Given this list of marker genes STAU1, FGD6, TMEM33, NTS, LRRC4C, PIK3CA, SEMA3A, RHOU, ENPEP, MTERF1, TRHDE, MSL3 (NCBI Gene Id 25867), RIOK2, POLI, PI15, KAZN, PPP2R3A, GABRG2, PTPN21, AMD1, PABPC3, PEX1, ZFP91, MARCHF1, FNDC3B, XRN1, ARHGAP5, C2orf66, HCN1, CYBRD1, PABPC4L, FAM13C, AKAP12, ATR, PPP4R2, ABHD5, MAP3K20, PATL2, TOR1AIP2, CWC15, ELOVL5, DFFA, UBAP1, NMU, ETV1, SLC4A7, HCFC1, KCNA4, NGLY1 (N-glycanase 1), TUSC1, KCNMA1, AASDH, HS3ST1, ZNF99, SH3TC2, PEX5L, ANOS1, RFPL1, EPHA5, MAP4, RSBN1, KRT38, EGLN1, ARID2, FXYD3, MBNL2, SLC1A1 (solute carrier family 1 member 1), LATS1, USH2A, RDX, MKRN1, ZDHHC20, TMEM263, GK5, STC2, PID1, HADHB, ZMYM5, YME1L1, CHUK, RBM18, MFSD14A, VCAN, FAM210B (NCBI Gene Id 81895), ZBTB20, LEP, GALNT4, IFNG, ADGRL3, YES1, SUSD5, LGSN, NRN1, ZNF148, PITRM1, SPRED1 (NCBI Gene Id 161742), LRRC31, KRT222, UNC80, NUDT15, COPS3, FUT9, KNSTRN, HNRNPLL, NBR1, SLC25A46, CISD1, DLK1, ARL5B, KIF2A, VPS72, LAMA4, PPM1K, GOPC, TMEM229A, SLITRK4, CCNT2, SOX11, NEK7, PTHLH, PSD3, NBEA, DIS3, ELAVL4, CYYR1, SLC28A3, CCL7, RNF6, LHFPL2, CAPN14 (calpain 14), TNKS2, APOOL, IMPG2, SCP2, ZFYVE16, FMO3, LGR4, KCNQ5, FKBP7, ZNF704, CTNND1, CD44 (NCBI Gene Id 960), UBE2G2, CCNY, PCDH7, POC1B-GALNT4, NTNG1, RNF217, GLDN, ZNF267, TJP1, C1orf141, MRRF, MOB1B (NCBI Gene Id 92597), PPP1R15B, FBXL17, PARG, MINDY2, SEPHS2, ASNS (NCBI Gene Id 440), here is a description of the gene set: Genes predicted to be targets of miRBase v22 microRNA hsa-miR-8061 in miRDB v6.0 with MirTarget v4 prediction scores > 80 (high confidence targets). from publication Chen Y, Wang X (PMID 31504780) species: Homo sapiens Human Gene Set: MIR8061